Given this list of marker genes Pten, Trp63, Apc, Foxa1, Serpinf1, Hoxd13, Wdr77, Stat5a, Nog, Cdkn1b, Ahr, Fgf10, Wnt5a, Sulf1, Gli3, Mmp2, Ar, Psapl1, Cyp19a1, Smarcc1, Esr1, Sox9, Prlr, Hoxa11, Ube3a, Ptch1 (patched 1), Psap, Plaur, Cd44, Cyp7b1, Esr2, Notch1, Stk11 (NCBI Gene Id 97678), Fkbp4, Hoxb13, Bmp4, Hoxa13, Rln1, Fem1b, Rarg, Rxra, Sfrp1, Frs2, Bmp7, Eaf2, Rara, Tnc, Nkx3-1, Id4, Serpinb5, Hoxa9, Fgfr2, Gli2, Shh, Hoxa10 (NCBI Gene Id 15395), Ctnnb1, Igf1r, Igf1, Plag1, Gli1, here is a description of the gene set: Mouse Gene Set: GOBP_PROSTATE_GLAND_DEVELOPMENT The process whose specific outcome is the progression of the prostate gland over time, from its formation to the mature structure. The prostate gland is a partly muscular, partly glandular body that is situated near the base of the mammalian male urethra and secretes an alkaline viscid fluid which is a major constituent of the ejaculatory fluid. studied in species Mus musculus